Given this list of marker genes UBBP5, MIR548AS, ENSG00000287159, DPPA3P3, KRT18P27, MIR18A, LINC02336, OBI1, RNU6-67P, ENSG00000271776, LINC00410, LINC01040, RNA5SP35 (NCBI Gene Id 100873367), BRK1P2, MOB1AP1, MIR4500, LINC00373, POU4F1, GPC6-AS1, CCT5P2, SLITRK1, RNU6-75P, MIR19A, PTMAP5, LINC01080, LINC00353, BCAS2P3, RPL7L1P1, RNU6-61P, DDX6P2, MIR4500HG, NDFIP2 (Nedd4 family interacting protein 2), FAR1P1 (NCBI Gene Id 100128011), RNU6-77P, LINC00375, ARF4P4, NIPA2P5, LINC00382, LINC00397, ENSG00000302433, TRIM60P13, GPC5-AS2, HIGD1AP2, UBE2D3P4, TET1P1, SLITRK5, ENSG00000200733, ENSG00000303705, MIR20A, LINC00559, HSPD1P8, LIN28AP2, HNRNPA1P29, RNU4ATAC3P (RNA, U4atac small nuclear 3, pseudogene), LINC00380, MIR17HG, PPIAP23, TXNL1P1, GPC6-AS2, GPC6, LINC00333, LINC01047, RPL29P29, LINC01068 (long intergenic non-protein coding RNA 1068), NDFIP2-AS1, GPC5-IT1, LINC00433, PWWP2AP1, LINC00430, RPL21P111, SP3P, RNA5SP34, MIR622, GPC5, LINC00363, GPC5-AS1, SLITRK6, RNA5SP33, LINC01049, PEX12P1, LINC00440, RBM26-AS1, HNRNPA1P31, LINC00351, FABP5P4, SPRY2, MIR17, MIR19B1, LINC01038 (NCBI Gene Id 102724076), GYG1P2, RBM26, MTND5P3, LINC00564, VENTXP2, MTND4P1 (MT-ND4 pseudogene 1), GRPEL2P1, LINC00379, LINC00331, MIR92A1, LINC00377, here is a description of the gene set: species: Homo sapiens Human Gene Set: chr13q31